The following is a description of a gene set: Mouse Gene Set: TABULA_MURIS_SENIS_SUBCUTANEOUS_ADIPOSE_TISSUE_ENDOTHELIAL_CELL_AGEING from publication Tabula Muris Consortium (PMID 32669714) species: Mus musculus, and this is the list of marker genes: Ctnnbip1, Tmsb10, Rhoc, Bst2, Cd74, Lsm2, Ecscr (endothelial cell surface expressed chemotaxis and apoptosis regulator), Serping1, Hexb, Npr1, Shisa5 (NCBI Gene Id 67794), Map3k1, Tomm6, Aff4, Cfl1, Cables2, Pde4c, Smco4, Hyou1, Psmb8, Dhrs7, Brd9, Ptma, Ppp4c, Arsb, Mbp, Bsg, Mgp (NCBI Gene Id 223886), Dusp3, Arhgef2, Gstm1, Irf2bpl, Plekha3, Gadd45gip1, Ccnd2, H2az2, Dpp9, Nfkbid, Gja4, Sipa1l1, Krt14, Coro1c, Kdm6b, Maf1, Cd63, Sec24c, Tle5, Grap (GRB2-related adaptor protein), Ago2, Hmg20b, Psmd7, Spef1, Gstp1, Snrpc, Cfh, Mxra8, Bcl3, Scand1, Mir503hg, Marcks, Lgals7, Zfp771, Ltbr, Apoe, Laptm5, Nfkbib, Map1lc3a, Fxyd6, Klf13, Norad, Dpysl2, Rad9a, Mmp24os1 (NCBI Gene Id 613262), Ece1, Sdc3, Ctc1, Clpp, Tpm3, Dcn, Reep5, Csrp1, Tmed9, Ppp1r9b, Vasp, Slc39a6, Lhfpl6, Sdc4, Arf5, Sf3b2, Egfl7, Mapkapk2, Eeig1, Rnf167, Cracr2b, Selplg, Msx1, Klf7, Tlnrd1, Znhit1, Bcl7c, Gnb1, Gpr34, Ctss, Hmox1, Ssbp4, H2-Aa, Aldh2, Anapc11, Hlx, Mall, Grina (NCBI Gene Id 66168), Ap3d1, Crispld2, Nabp2, Ap2s1, Gigyf1, Tex261, Tacstd2, Paip1, H2-Ab1, Zbtb7a, Prr13, Mbtps1, Arl6ip1, Rnf125, Abhd17a, Adam17, Smap2, Csf1r, Rbm26, Taok2, S100a16, Jund, Ubb-ps, Ptms, Rnf10, Gsn, Rtcb, Ltbp4, Bri3, Krt6a, Lyz2, Lbp, Ifit2, Eif5a, F3, Tcf15, Cd53, Efna1, Cyb561d1, Sgf29, Hdac7, Slc37a3, Lrrc8a, Pcdh1, Selenom, Tbcb, Palm, Zbtb16, Man1a2, Rpl13a, Ctdnep1, Srsf9, Clic4, Swi5, Cd9, Kmt2b, Aqp1, Sncaip, Pfn1